Given this list of marker genes Hbs1l, Cnot6, Csde1, Pelo, Gtpbp2 (NCBI Gene Id 56055), Tesk1, here is a description of the gene set: studied in species Mus musculus The chemical reactions and pathways resulting in the breakdown of the transcript body of a nuclear-transcribed mRNA with stalls in translation elongation. Mouse Gene Set: GOBP_NUCLEAR_TRANSCRIBED_MRNA_CATABOLIC_PROCESS_NO_GO_DECAY